Given this list of marker genes ZSCAN26, YAP1, MCM3AP, ARHGEF3, ODAD1, UNC45A (NCBI Gene Id 55898), KLC4, QPCTL, HSPA8, RAB4A (RAB4A, member RAS oncogene family), CYP2E1, RER1, CDIP1, MX2, AP1S3, TM4SF19-DYNLT2B, DLC1, CPQ, EML2, CNTROB (NCBI Gene Id 116840), CCDC85C (coiled-coil domain containing 85C), ZNF425, MPHOSPH9, NPNT, CD164 (NCBI Gene Id 8763), SEC31A, CWC25, TEF, PRKCZ, TLCD3B, FTO, ATP8B3 (ATPase phospholipid transporting 8B3), SMAD6, ITGAL-AS1, CYB5R2, JAK1, TP53TG3GP, EFHC1, IRX4-AS1, CEP85, RUNX1T1, TMEM191A, DCAF16, KLHL26, MRPL19 (mitochondrial ribosomal protein L19), GALNTL5, NDST4, PPP2CA-DT, PLK2, CYP1B1-AS1, PPOX, PPP2R3B, LINC01596, POLR1F, LINC01476, DCUN1D5, DKK2, MIR3665, ZNF254, RPS19, C1orf21-DT, LIM2-AS1, MIR607, SAPCD2, BCORL1, ICAM4, FUT8-AS1, DRC3, MAN1B1-DT (MAN1B1 divergent transcript), SKIC3, FMO4, TRMT10B, PRKCI, C2CD5, IL6ST, EARS2, AHRR, SDHD, AKAP6, KIF18B-DT, DYNC2H1, GTPBP3, ART1, PTPN2, RNU6-166P, CCL4, GNG4, DPPA3P10, ZNF398, NPHS1, RABGAP1L, ENAH, NORAD, SNORA17B, ZNF862, MARK2P4, KSR1, TRIM15 (NCBI Gene Id 91943), WARS2-AS1, MARCHF8, TIMM8B, REN, MTND5P8, GSE1, SLC35F2, MOCOS, LRP11, C18orf21P1, FAF2, TOB2, CTNNA2, RND1, RPL10A, GALK2 (galactokinase 2), LINC02030, DNAJC10, MIPOL1, NLE1, GGNBP2, TAP2, MRGPRX5P, FNBP1, MAML1, MKNK1, PLEKHG3, MYO18A, RAB4B, WDR36, RNF20, MAPKBP1, SELENBP1, FNTB, MPDU1-AS1, HCG27, RN7SL521P, CCN5, LRRC8A, GM2A, RAI14, SLC11A2, NAPSA, RNU4-2, AP2A1, CDK13-DT, USP40, SPATS2L, BAIAP2L1, CCNI, AZGP1, CHURC1, RNU6-74P, HNRNPMP2, CMKLR2-AS, ANK3, DENND3, ARIH1 (ariadne RBR E3 ubiquitin protein ligase 1), MTFMT, PHACTR4, LINC00869, ENSG00000181123, LEPR, LRRD1, HIVEP3, PLK1, TOM1L2, TLCD1, NDUFA5, ASS1P5, METTL16, TRMT5, ZNF491, ZNF155, SP2-AS1, ZNF45, TMEM165, MT-TP, RPA2, HERPUD2, ZHX3, DUSP4, CNBD2, ERAL1, ARMC5, CIZ1, CDKN1B, PDXP, CIT, R3HCC1L (NCBI Gene Id 27291), PTBP3, PQBP1, S100A4, PRKAR1A, THAP9-AS1, PPP1R14D, TNFRSF12A, CPLX2, LINC01182, RPL36, ARID1A, MAN2C1, HNRNPM (heterogeneous nuclear ribonucleoprotein M), ZNF775, EXOSC2, GLCE, SYT17, TMEM98 (NCBI Gene Id 26022), JADE2, UBE2G1, HNRNPF, SOS1, RAB30, RNU5E-6P, C1orf21, PPP2CA, IGHVII-30-1, FAM76B, C17orf49, ILVBL, CDS1, GSTO1, LIPA, GPR143, DXO, TRIM9, SMG1P3, EIF2S1, SYCE2, IMMP2L, LINC03019, LINC00581, MIR6070, WDR35, AQR, SH3BP5, GLG1, MTND5P11, TBX3, KDM8, MTO1, SNORA17A, PBX1, MTRF1L, UBA5P1, CRYZL1, KANSL1, NCAPG, ZNF382, ZNF544, ENSG00000237429, BORCS7, MAN1B1, LINC01359, XNDC1N, SNHG17, TRAJ27, CD300LG, FAU, WDR26, CPA5, ZNF675, DUSP10, ACER3, CDKN3, ECE1, GIT2, USO1, TRIM36, KIF20B, ISG15, CADM4, IRF2BP2, COSMOC, TBCCD1, ZFP64, PTCH2, MAP1B, LINC01010, SASH1, KAT8, ARL16, LINC01623, SDC4P, DNAJB11, MED10, ABCD2, UTP4 (UTP4 small subunit processome component), BLOC1S5, LINC01235, NNT, PPP1R12C, KBTBD4, SMARCD2, C5orf34, NYAP1, DNAI4, SLC38A6, DDX59, MFSD4B-DT, STOML2, MT-RNR1, RNU6-695P, NT5E, ABHD3, APLP1, SPTAN1, STC1, CFAP410, LINC02598, FTSJ3, ALDOA, ATP4A, MTCO3P12, VKORC1, FUT8, ZGRF1, ZNF706, LINC01960, FMN2, RNU6-254P, ANKRD6, PLEKHH1, ERLIN1, LINC01763 (NCBI Gene Id 105378854), IPP, HAPLN2 (NCBI Gene Id 60484), MTFR1L, NCOR2, SRSF6, ENSG00000263280, CC2D2B, EVC, LEPROT, NDEL1, ADA, MLLT3, TXNL1, ITPR1, ST3GAL3, FILIP1, PKMYT1AR, ZNF230-DT, FCHO2, TMPRSS4, KCNK1, ZNF705A, ACOT7, EEF1A1P19, RNU6-1003P, STIM1, PCNX2, GCATP1, ZNF106, AP3D1, ZC3H7A, SF3B3, PSMC5, PAPSS2 (3'-phosphoadenosine 5'-phosphosulfate synthase 2), TCAM1P, SDC4, SLFN12, MORN1, FBH1, FRMD7, BOLA1 (NCBI Gene Id 51027), HSPA12A, COL6A1, NKAPP1, RNU7-24P, GLT8D2, GSR, BLOC1S5-TXNDC5, AATBC, VAV3, ABHD17A, PDXP-DT, ELP2, ENSG00000247416, SLAIN1, LINC01533, SAMD13, NDUFS3, STK32B, NMNAT1, ZNF799, DNAH17, SLC26A6 (NCBI Gene Id 65010), FBXL15, AIG1, BTBD16, GMDS, PGAP3, ABCF3, MAN2A1-DT, TP53, CEMP1, BORCS7-ASMT, RHOQ, RETSAT, SYCE1, SMIM7, CAV1, SIDT1, MIB1 (MIB E3 ubiquitin protein ligase 1), EFCAB7, GNB2, PTGES3L-AARSD1, ADAT1, COPS3 (NCBI Gene Id 8533), WBP2, KAT5, FAM151B-DT (NCBI Gene Id 121232370), FNDC3A, YIPF6, WDR1, COL12A1, RNU6-206P, MPDU1, AGMAT, RNU6-1340P, APP, DIXDC1, FUNDC1, FLT3, CNN3, MYO1A, ARRB2, ATXN7L3B, CMTR2, ATP6V1D, AVPR2, SNHG30, UBC, ANO8, ANKRD16, CEP120, ENSG00000223834, NPR3, CHURC1-FNTB, PGM2, FREM2, VWA7, ZNF573, HYAL3, FAM210B, ENPP1, ACAT2, KDM1A (lysine demethylase 1A), HEBP2, RAB30-DT, NKAIN1, ITGB3BP, ZNF234, ZNF879, MAN1A2, RNU6-847P, TMEM44-AS1, PRELID3A, DHDDS, MIR4537, PGAP4, DCAF15, UBFD1, CBX4, LINC02765, TOMM7, CEP57, NDUFAF6, IGHA2, SUPT3H, MIR4470, EXO5-DT, ZNF230, MICALL1, HGS, KDSR, ZFPM2-AS1, CLINT1, PLS1, KCNN3, GDI2, IL17RA, ASPH, TMEM184C, TMEM184C-DT, MYCBPAP, MTMR1 (myotubularin related protein 1), NOL11, SNORD43, PEA15, ATP8A2, PPP2R5B, KHDRBS1, CACUL1, FBXL5, EXO5, LIPH, LSR, ITFG2-AS1, STKLD1, UBE3A, WDR7, CASP7, FYN, RNVU1-30, IFT122, LINC03099, MRPS23, EEF1AKMT2, ACOX1, PAWRP1, MAN2A1, YBEY, LZIC, SULT4A1, ZNF724, HBZP1, MIR3529, TRIM44, TRPM6, RARG, PHF14, SLC22A4, RPL27, MEFV, TGFB1, CTTNBP2NL, MTIF3, RNF150, COL9A1, UBE2Z, PRORP, KRBA2, PER2, SRSF2, SMO, ENSG00000244137 (NCBI Gene Id 107985359), MDN1, ZNF223, SCAND1, ANO3, EMC1-AS1, EIF4EBP1, NID1, LINC01641, MOK, ACACA, CP, MATK, NFATC2, DDN, SCARNA11, RBM15, RBL2, YWHAB (NCBI Gene Id 7529), VTA1, TM4SF19, ERCC6L, PTGES3L, MDM2, NOL6, SORBS3, ZNF224, SH3GL1, ASH1L, PURA, LNPEP, LINC02288, NNT-AS1, ZMYM5, MANEAL, ZNF433-AS1, FES, MFSD11, PPP2R3C, TMEM145, WNT8A, IQSEC2, PCDHGA11, PNPO, BMP7, RPL3, TRAPPC1, RAB11FIP1P1, KRIT1, CHD4, TMEM202-AS1, LINC02352, STX4, PSD, ZNF554, ZNF609, E4F1, DNAH10, ZSWIM6, SLC25A19, MTMR9LP, MIR4520-2, BBLNP1, ETHE1, APEX2, LINC01607, SPEN, TRAPPC8, UBR4, RABGAP1L-DT, MFSD4B, DRAM1, MERTK, KATNA1, ENTPD1-AS1, RFTN1, POLD3, PPP1R1B, PLA2G15, ITSN1, G3BP2, ZNF227, RNA5SP441, GSDMA, DISP3, SNRPD2, ST6GAL2, ANP32A, RAD54L, RPL7AP6, GALNT6, KANSL1-AS1, UBE2E3, ENSG00000255647, CLEC5A (C-type lectin domain containing 5A), NCAM1, SDAD1P3, RPL26, OACYLP, MIR1273C, LYSMD3, TMEM38A, APBA1, SPON1, PLCD1, HRCT1, IFT140, RPUSD2, DLG1, RAD23A, MIA3, PDCD6P1, PCM1, ANGPTL6, TMT1B, FABP5P3, ARL8A, LINC02609, SPOUT1, ANO2, CACNA1C, ELMOD3 (NCBI Gene Id 84173), BORCS6, MIR4716, DDX3X, LINC02861, SAMD4B, FIBP, APP-DT, OLIG2, FEM1C, ANXA2, MED21, ZFHX2, RNU6-908P, CD160, SVIL, LUZP1, WRAP53, ZNF420, OR1X5P, FAM222B, MRPL49, THTPA, MIR627, BPNT2P1, NHERF2, TTC1, PRSS12, RRN3P1, RNF121, H1-10-AS1, ENSG00000265246 (NCBI Gene Id 124903956), CROCCP3, ASRGL1, CD8A, PDIA5, BCL7C, NOL4, CEP350, MORC3, RN7SL15P, SPRYD7, MIR5188, ANKIB1, PSMA6, ID4, PGM3, TIMM17B, STYK1, RIMS1, LINC01475, ARCN1, LINC02074, C6orf141 (NCBI Gene Id 135398), SLC25A45, KCTD7, BMI1, MT-TF, PPP1R12A, VTRNA1-3, UBR5, ITFG2, MALINC1, BRWD1, TMEM132E-DT, LRRC73, ISYNA1, CDK13, MCC (NCBI Gene Id 4163), PITX2, SCN3B, FAM200B, DNAJB12, QSER1, RPGRIP1L, CDK1, SEMA7A, RNF187, ZNF233, KDM3A, KCNAB3, BTAF1, SNHG7, ZFP82, STK19, TAFA2, SLC39A6, ZNF786, ZNF772, ERBB2, TBC1D10A, TTLL6, here is a description of the gene set: from publication Yevshin I, Sharipov R, Kolmykov S, Kondrakhin Y, Kolpakov F (PMID 30445619) species: Homo sapiens Genes containing one or more binding sites for (ZNF140) in their promoter regions (TSS -1000,+100 bp) as identified by GTRD version 20.06 ChIP-seq harmonization. Human Gene Set: ZNF140_TARGET_GENES